The following is a description of a gene set: Human Gene Set: HP_DECREASED_CLASS_SWITCHED_MEMORY_B_CELL_PROPORTION species: Homo sapiens Decreased class-switched memory B cell proportion A reduction in the normal proportion of class-switched memory B cells (CD19+/CD27+/IgM+/IgD+) relative to the total number of B cells. Marginal zone B cells undergo limited somatic hypermutation and produce high-affinity IgM and some IgG, whereas class-switched memory B cells synthetize IgG, IgM, and IgA., and this is the list of marker genes: REL, CD19, CTNNBL1, ICOSLG, SOCS1, LRBA, FNIP1, LCP2, MAP3K14 (mitogen-activated protein kinase kinase kinase 14), PLCG2, PRKCD, ICOS, TET2, IRF2BP2, HYOU1, IL6R, IL21, PIK3CD